The following is a description of a gene set: Human Gene Set: MIR365A_3P_MIR365B_3P Genes predicted to be targets of miRBase v22 microRNA hsa-miR-365a-3p, hsa-miR-365b-3p in miRDB v6.0 with MirTarget v4 prediction scores > 80 (high confidence targets). studied in species Homo sapiens from publication Chen Y, Wang X (PMID 31504780), and this is the list of marker genes: SOCS5, SGK1, TBK1 (TANK binding kinase 1), BCLAF3, TMEM106C, YRDC, SH3PXD2A, KANSL1, UBP1, NR1D2, USP48, NUDT3, MYLIP, SSH2, MYLK, ARHGAP12, TRHDE, ANKS1A, RGS20, FAM91A1, CBFB, JADE2, GPC6, ADD3, DLAT, UBAC2, UNC5D, ZNF644 (NCBI Gene Id 90858), E2F2, EHF, KLRD1, DNAJB4, TMOD3, NR4A2, SEMA3A, AMMECR1, RPS10-NUDT3, PRLR, PRPF40A, BRD10, RAPGEF4, IL1RAP, TFDP1, PTPRJ, UBE2D3, LRIT2, DDX60L, ADM, PIK3R3, STARD4, DLX3, HDAC9, SNX12, LPAR5 (lysophosphatidic acid receptor 5), WDR37, CREBRF, GON7, ZNF680, SRGAP1, SIX4, ZFP28, HHIP, OXR1, MAPK1, EYA2, SIAH3, NFIB, VGLL3, ING3, AFAP1L1, KCNJ2, HMGCS1, RASD1, PCNP, RICTOR, IGFBP7, ANKRD11, SLC43A3, ZNF493, CREB5, ESRRA, NR3C2 (nuclear receptor subfamily 3 group C member 2), MEX3A, GLIPR1L2, SLC30A7 (NCBI Gene Id 148867), WDR90, HOXA9, USP33, ZNF782, TIAM2 (TIAM Rac1 associated GEF 2), PPFIA2, NUFIP2, KLF3, GRAMD1C, TLL2, EFEMP1, RAC1, ROR1, PRUNE2, SYPL1, ZNF124, ANKRD17, ARRB2, EPC1, PLCB4, SESTD1, ARK2N, MEAK7, MAK, ZNF148 (NCBI Gene Id 7707), ACVR1, UGCG, LYSMD3 (LysM domain containing 3), TECPR1